The following is a description of a gene set: Human Gene Set: REACTOME_APC_C_MEDIATED_DEGRADATION_OF_CELL_CYCLE_PROTEINS studied in species Homo sapiens APC/C-mediated degradation of cell cycle proteins, and this is the list of marker genes: SEM1, PSMC2, PSMC6, CDK2, FZR1, CDC23, PSMA3, PSMB6, UBC, PSMD6, PSMC1, FBXO5, ANAPC11, UBB, CDC27, PSMC3 (proteasome 26S subunit, ATPase 3), BTRC, PSMD14, PSMA7, PSMD3, PSMA6, CCNB1, PSMB5, CDK1, PSMB1, PSMB3, PSMD1, ANAPC15 (anaphase promoting complex subunit 15), CDC20, PSMA4, PTTG1, PSMA1, ANAPC2, PSMD11, CDC14A, ANAPC5, ANAPC4, PSMB2, PSMD12, AURKB, ANAPC1, CUL1, UBE2C, CCNA1, ADRM1, PSMD13, SKP2, PSMB7, UBE2D1, NEK2, PSMD8, UBA52, BUB1B, PSMA2, CCNA2, PSMB4, UBE2E1, CDC26, UBE2S, CDC16, PSMD2, SKP1, PSMC5, ANAPC10, PSMD7, PSMC4, ANAPC7, RPS27A, RB1, BUB3, PSMA5, PLK1, ANAPC16, AURKA, MAD2L1